Given this list of marker genes RPL24, RPS6 (NCBI Gene Id 92956), TPT1, RPS12, UBC, HNRNPK, EEF1G, EIF4G2, RPL30, RPL17, RPS25, H3-3A, UBB, RPS3A, DNAJB6, CFL1, RPL27A, DAZAP2 (DAZ associated protein 2), MYL6, RPL19, RPL6, RPL31, RPL13, RPS27, SLC25A6, RPS24, FBXO7, MCL1, SRP14 (NCBI Gene Id 6727), RPL22, RPS27A (NCBI Gene Id 6233), RPS20, NACA, RPL5, EEF2, H3-3B, H1-10, RPL18, RPS15A, FAU, PCBP2, RPL7, EEF1B2, RPL10A, EIF4A2, NXF1, RPL21, DDX5, JUND, BTF3, IER2, RPL27, RBM3, RPL11, CLIC1 (chloride intracellular channel 1), RPL34, RHOA, RPL9, ACTG1, RPL13A, RPLP2, RPS7, RPL36A, LSM14A, here is a description of the gene set: Human Gene Set: MORF_JUND Neighborhood of JUND jun D proto-oncogene in the MORF expression compendium Neighborhood of JUND studied in species Homo sapiens